The following is a description of a gene set: Human Gene Set: LI_PBMC_MENACTRA_AGE_18_45YO_ANTI_DT_ANTIBODY_CORRELATION_PROFILE_3DY_DN from publication Li S, Rouphael N, Duraisingham S, Romero-Steiner S, Presnell S, Davis C, Schmidt DS, Johnson SE, Milton A, Rajam G, Kasturi S, Carlone GM, Quinn C, Chaussabel D, Palucka AK, Mulligan MJ, Ahmed R, Stephens DS, Nakaya HI, Pulendran B (PMID 24336226) Many vaccines induce protective immunity via antibodies. Systems biology approaches have been used to determine signatures that can be used to predict vaccine-induced immunity in humans, but whether there is a 'universal signature' that can be used to predict antibody responses to any vaccine is unknown. Here we did systems analyses of immune responses to the polysaccharide and conjugate vaccines against meningococcus in healthy adults, in the broader context of published studies of vaccines against yellow fever virus and influenza virus. To achieve this, we did a large-scale network integration of publicly available human blood transcriptomes and systems-scale databases in specific biological contexts and deduced a set of transcription modules in blood. Those modules revealed distinct transcriptional signatures of antibody responses to different classes of vaccines, which provided key insights into primary viral, protein recall and anti-polysaccharide responses. Our results elucidate the early transcriptional programs that orchestrate vaccine immunity in humans and demonstrate the power of integrative network modeling. studied in species Homo sapiens Genes down-regulated in peripheral blood mononuclear cell 3d vs 0d in adults (18-45) (anti-DT antibody-correlation profile) after exposure to Menactra, time point 3D, and this is the list of marker genes: IL1B, CXCL8 (NCBI Gene Id 3576), C1R, CCL20, PRL, CFH, IFNA14, C1QC, C7, C3, C2, LAMC2, PTX3, TNR, A2M, C1S, GPX1, IMPG2, IL6